Given this list of marker genes Hbb-bh1, Hbb-bt, Hbb-bh0, Hba-a1, Hbq1b, Hba-a2, Hba-x, Hbq1a, Hbb-y, Hbb-bh2, Hbb-bs, here is a description of the gene set: species: Mus musculus Binding to a haptoglobin, any alpha2 globulin of blood plasma that can combine with free oxyhemoglobin to form a stable complex. Mouse Gene Set: GOMF_HAPTOGLOBIN_BINDING